Given this list of marker genes Cyp2f2, Egr1, Aox4, Map2, Wdfy1, Stk25, Elovl1, here is a description of the gene set: Mouse Gene Set: TERAO_AOX4_TARGETS_HG_DN from publication Terao M, Kurosaki M, Barzago MM, Fratelli M, Bagnati R, Bastone A, Giudice C, Scanziani E, Mancuso A, Tiveron C, Garattini E (PMID 18981221) The mouse aldehyde oxidase AOH2 (aldehyde oxidase homolog 2) is a molybdoflavoenzyme. Harderian glands are the richest source of AOH2, although the protein is detectable also in sebaceous glands, epidermis, and other keratinized epithelia. The levels of AOH2 in the Harderian gland and skin are controlled by genetic background, being maximal in CD1 and C57BL/6 and minimal in DBA/2, CBA, and 129/Sv strains. Testosterone is a negative regulator of AOH2 in Harderian glands. Purified AOH2 oxidizes retinaldehyde into retinoic acid, while it is devoid of pyridoxal-oxidizing activity. Aoh2(-/-) mice, the first aldehyde oxidase knockout animals ever generated, are viable and fertile. The data obtained for this knockout model indicate a significant role of AOH2 in the local synthesis and biodisposition of endogenous retinoids in the Harderian gland and skin. The Harderian gland's transcriptome of knockout mice demonstrates overall downregulation of direct retinoid-dependent genes as well as perturbations in pathways controlling lipid homeostasis and cellular secretion, particularly in sexually immature animals. The skin of knockout mice is characterized by thickening of the epidermis in basal conditions and after UV light exposure. This has correlates in the corresponding transcriptome, which shows enrichment and overall upregulation of genes involved in hypertrophic responses. species: Mus musculus Genes down-regulated in Harderian gland tissue upon knockout of AOX4.